The following is a description of a gene set: Human Gene Set: chr6q14 studied in species Homo sapiens, and this is the list of marker genes: COX7A2, IBTK, MYO6, SMARCE1P2, RNU6-84P (NCBI Gene Id 106479603), ENSG00000272008 (NCBI Gene Id 124901355), RNU6-1016P, RNU6-248P, CGA, RNU6-261P, RPL17P25, PGM3, ZNF292, RPS6P7, BCKDHB, PRSS35, DUTP5, SH3BGRL2, HSPD1P10, RAB1AP2, RN7SL643P, LINC02535, HMGN3-AS1, SNX14, TTK, HMGN3, CEP162, RNU4-72P, GAPDHP63, HMGB1P39, RNU6-130P, MEI4 (NCBI Gene Id 101928601), IMPG1 (NCBI Gene Id 6673), LINC02857, SNORD50B, LINC01611, DBIP1, RPL26P20, RPSAP72, TPBG, AK4P5, LINC02542 (long intergenic non-protein coding RNA 2542), MIR4463, RPL35AP18, SNORA70, COL12A1, SMIM11P1, RPL31P32, HTR1B, RPL7P27, RNU6-1338P, LAP3P1, ENSG00000221332, UBE3D, RIPPLY2, TPT1P6, SYNCRIP, IRAK1BP1, RCN1P1, DOP1A, TENT5A, RNA5SP209, H3P27, LCAL1, ENSG00000271945, RNU1-34P, TMEM30A-DT, KRT18P64, RPL7P29 (ribosomal protein L7 pseudogene 29), UBE2V1P15, CYB5R4, MTHFD2P2, SENP6, TBX18, RN7SKP163, NT5E, MRAP2, RNU6-155P, HTR1E, ELOVL4, PHIP, TMEM30A, SNAP91, ENSG00000297199, TBX18-AS1, ME1, RN7SKP209, NDUFA5P9, RNU4-12P, FILIP1, LCA5, LINC01526, PKMP3, RNA5SP210, LINC01621, RWDD2A, LINC02540, SNHG5